Given this list of marker genes Ezh2, Clu, Bcl2, Ccne1, Met, Ctsb, Cdkn1a, Igfbp2, E2f4, Hpn, Ar, Mki67, Amacr, Mta1, Klk1b3 (NCBI Gene Id 18050), Fn1, Ceacam1, Ets1, Insr, Vav3, Tff3, here is a description of the gene set: studied in species Mus musculus To identify biomarkers that discriminate the aggressive forms of prostate cancer, we performed gene expression profiling of prostate tumors using a genetically engineered mouse model that recapitulates the stages of human prostate cancer, namely Nkx3.1; Pten mutant mice. We observed a significant deregulation of the epidermal growth factor and mitogen-activated protein kinase (MAPK) signaling pathways, as well as their major downstream effectors--the activator protein-1 transcription factors c-Fos and c-Jun. Forced expression of c-Fos and c-Jun in prostate cancer cells promotes tumorigenicity and results in activation of extracellular signal-regulated kinase (Erk) MAPK signaling. In human prostate cancer, up-regulation of c-Fos and c-Jun proteins occurs in advanced disease and is correlated with Erk MAPK pathway activation, whereas high levels of c-Jun expression are associated with disease recurrence. Our analyses reveal a hitherto unappreciated role for AP-1 transcription factors in prostate cancer progression and identify c-Jun as a marker of high-risk prostate cancer. This study provides a striking example of how accurate mouse models can provide insights on molecular processes involved in progression and recurrence of human cancer. from publication Ouyang X, Jessen WJ, Al-Ahmadie H, Serio AM, Lin Y, Shih WJ, Reuter VE, Scardino PT, Shen MM, Aronow BJ, Vickers AJ, Gerald WL, Abate-Shen C (PMID 18381418) Mouse orthologs of human prostate cancer tumor markers which were deregulated in mice heterozygotic for both NKX3.1 and PTEN. Mouse Gene Set: OUYANG_PROSTATE_CANCER_MARKERS